The following is a description of a gene set: species: Homo sapiens Human Gene Set: chr16q23, and this is the list of marker genes: OSGIN1, ADAMTS18, CFDP1, MON1B, ENSG00000261838, NECAB2, CLEC18B, DYNLRB2-AS1, BCO1, CDH13-AS2, RPL21P118, CDYL2, LINC02131, PDPR2P, ADAT1, KARS1, RN7SKP176, PSMD7, WWOX, MIR6504, LSM3P5 (LSM3 homolog, U6 small nuclear RNA and mRNA degradation associated pseudogene 5), PPIAP51, HSPE1P7, MPHOSPH6-DT, TERF2IP, ZFP1, PPIAP49, CENPN, MIR4720, CMIP, MIR3182, CNTNAP4, ATMIN, WDR59, PSMD7-DT, MIR8058, ENSG00000278058, TMEM170A, ENSG00000260832, CDH13-AS1, RNA5SP432, HSBP1, SLC38A8, GLG1, PPIAP50, GCSH, CPHXL, TMEM231P1, LDHD, CDH13, CHST6, SYCE1L, RPL18P13, RNU6-758P, ENSG00000261285, C16orf46-DT, DYNLRB2, VAT1L, ATP5PBP7, PKD1L2, CTRB1, MIR7854, HSD17B2, ENSG00000260862, MIR4719, ENSG00000290455, NUDT7, ENSG00000261170, LINC02125, LINC01227, BCAR1, MLYCD, MTCYBP28, ZNRF1, RNU6-237P, CHST5, ENSG00000299389, GAN, CTRB2, DUXB, FA2H, RPS3P7, HSD17B2-AS1, ENSG00000260733, CMC2, ENSG00000303013, SDR42E1, CPHXL2 (cytoplasmic polyadenylated homeobox like 2), GABARAPL2, TMPOP2, NPIPB15, MLKL, WWOX-AS1, SNORD33, RFWD3, CLEC3A, RNA5SP431, TMEM231, CEDORA, CENPN-AS1, ARLNC1, RN7SL134P, RN7SL520P, KRT8P22, MPHOSPH6, LINC01229, RN7SKP233, RNA5SP430, ENSG00000252122, ENSG00000286894, MAFTRR, RNU6-1191P, MAF, VN2R10P, RN7SKP190, C16orf46, PCHILR, PLCG2, ENSG00000288821, LINC01228